Given this list of marker genes SOX2, HMBOX1, INTS9, HTN1, HSCB, ALKBH4, PPCDC, STAU1, XPO1, FGF14, JARID2, BRD8, CNOT4, TMEM150A, PDIA5, ANKS1A, FNTB, KBTBD6 (NCBI Gene Id 89890), NRAP, TMEM245, TMOD3, SPEF1, LRWD1, TRAF7, DNAJC17, CARD9, ZFYVE19, HIRIP3, MRPL50, C19orf44, TBXT, CERT1, TOP3A, ZCCHC8, COL25A1, TMEM115, MYL6B, DPF1, SEC11C, CA11, NUMB, LINC03124 (NCBI Gene Id 90559), ZNF189, MSL3, ADM, DNAJC14, ESPL1, APH1A, FOXO1, ZNF274, IZUMO1, WDTC1, SF3B4, PALS2, SMCR8, AP2M1, ADO (NCBI Gene Id 84890), ACP6, FHIT, NHERF1, ATL3, SLC38A9, TRPS1, NEDD8 (NCBI Gene Id 82917), LIG1, DHX30, ZC4H2, PHF13, FYCO1, ARMC5, ZSWIM9, BCL11A, STMN2, GNAI2, BCKDK, CEP97, SNTG1, GRWD1, TMEM69, INO80E, KAT2A, CCNA2, BBX, FAM120C, COPG2, KMT2D, POLK (NCBI Gene Id 51426), NFXL1, SYT3, RASD1, HSPB9, CCPG1, AHCYL2, PSMD11, LRRC74A, RCN3, CALR3, ZNF691, RNF17, SLC10A7, RAD54L2, TBC1D10B (NCBI Gene Id 26000), KCNJ2, TSPAN6, GMPR2, MVB12A, here is a description of the gene set: species: Homo sapiens Genes having at least one occurrence of the highly conserved motif M105 ACTWSNACTNY in the regions spanning 4 kb centered on their transcription starting sites. The motif does not match any known transcription factor binding site. Human Gene Set: ACTWSNACTNY_UNKNOWN Comprehensive identification of all functional elements encoded in the human genome is a fundamental need in biomedical research. Here, we present a comparative analysis of the human, mouse, rat and dog genomes to create a systematic catalogue of common regulatory motifs in promoters and 3' untranslated regions (3' UTRs). The promoter analysis yields 174 candidate motifs, including most previously known transcription-factor binding sites and 105 new motifs. The 3'-UTR analysis yields 106 motifs likely to be involved in post-transcriptional regulation. Nearly one-half are associated with microRNAs (miRNAs), leading to the discovery of many new miRNA genes and their likely target genes. Our results suggest that previous estimates of the number of human miRNA genes were low, and that miRNAs regulate at least 20% of human genes. The overall results provide a systematic view of gene regulation in the human, which will be refined as additional mammalian genomes become available. from publication Xie X, Lu J, Kulbokas EJ, Golub TR, Mootha V, Lindblad-Toh K, Lander ES, Kellis M (PMID 15735639)